Given this list of marker genes Pi4k2b, Mtmr2, Sacm1l, Sbf1, Pi4ka, here is a description of the gene set: Synthesis of PIPs at the ER membrane Mouse Gene Set: REACTOME_SYNTHESIS_OF_PIPS_AT_THE_ER_MEMBRANE studied in species Mus musculus